Given this list of marker genes RTL1, FA2H, SLC6A9, UBA5, PRRT2, PMP22, ATXN3, ERGIC1, TTR (transthyretin), PLAA, UBA1, SPR, HPSE2, VPS41, PIGA (phosphatidylinositol glycan anchor biosynthesis class A), NEB, KCNK9, FMR1, MAP3K20, EIF2AK2, ATP1A2, PNKD, ACTA1, PIK3CD, PDGFRB, EIF4G1, ATP1A3, PCDH19, NR4A2, PRDX3, DDHD2, DNA2, TNPO2, GATAD2B, SCN2A (sodium voltage-gated channel alpha subunit 2), TXNL4A, PLXND1, POMT2, TBP, ATXN8OS, PTRH2, ATCAY, MYH7, EBF3, SLC16A2 (NCBI Gene Id 6567), GLI3, MTMR14, CACNA1A, ATP6V1A, PIEZO2 (NCBI Gene Id 63896), MYH2, SCN1B, SLC30A10, SLC39A14, TK2, DNAJC13, SCYL2, DNMT3B, GIGYF2, EP300, FRG1, FKTN, GBA1, CCDC174, DNM2, PRNP, ATP7A, SGCB, GABRA1, SNCA, GIPC1, REV3L (REV3 like, DNA directed polymerase zeta catalytic subunit), CERT1, GMPPB, FTL, NOTCH2NLC, SELENON, TANGO2, TPM2, NECTIN1, PURA, STAC3, GABRG2, PLPBP, PANK2, TH, GOSR2, POMT1, PLA2G6, TWNK, GFM2, DLK1, PODXL, RRM2B, SLC6A8, SYNJ1, SCN9A, MAPT, ASXL3, PDE2A, SCN1A, CC2D1A, GLE1, HACD1, PTRHD1, SLC52A3, SMCHD1 (structural maintenance of chromosomes flexible hinge domain containing 1), KCNQ2, JAM2, PNPT1, MYH3, HLA-DQB1, VPS35, LRRK2, PAX6, ITPR1, POLG, FKRP, TRIM32, NEUROG1, MSTO1, ALDH7A1, DCTN1, TBCK, CP, CLTC, VAMP1, DPM2, TNNT1, CNTNAP1, LARGE1, MYMX, COL25A1, IRF6, MRE11, LAMA2, LRP12, SLC6A3, HOXB1, ADH1C, KLHL41, ATXN2, LRIG2, MEG3, MSX1, MT-TT, TPM3, PYROXD1, KCNH1, MYL1, RIPK4, DUX4, SLC9A7, RILPL1, HSPG2, KCNJ6, TECPR2, SNCAIP, CRELD1, UFC1, FBXO7, DUX4L1, ITGA7, SLC18A2, TAFAZZIN, RYR1, DNAJC6, ENSG00000288330, KCNQ3, CREBBP, UBE3A, PABPN1, POLG2, MECP2, BCL11B, ATP6AP2, PDGFB, MYL2, DMXL2, SLC20A2, TP63, SLC25A4, SPTBN4, KNSTRN (kinetochore localized astrin (SPAG5) binding protein), ATP13A2, here is a description of the gene set: species: Homo sapiens Human Gene Set: HP_ABNORMAL_FACIAL_EXPRESSION Abnormal facial expression